Given this list of marker genes Lsm3, Dis3l2, Samd4b, Kif5a, Caprin1, Zc3h12d, Lin28a (lin-28 homolog A), Cnot1, Syne1, Igf2bp2 (NCBI Gene Id 319765), Top1, Patl2, Cnot9, Cpeb1, Trim12a, Lsm2, Trim21, Eif4e, Carhsp1, Fam184a, Elavl1, Ago2, Samd4, Lsm6, Xrn1, Pan3, Psma4, Eif4e2, Psmc2, Ythdf3, Tnrc6c, Pum1, Trim30c, Dcp1a, Garre1, Cnot2 (CCR4-NOT transcription complex, subunit 2), Edc3 (NCBI Gene Id 353190), Trim30d, Psma2, Ybx1, Upf1, Sqstm1, Ddx6, Patl1, Mex3a, Cnot7, Dcp2, Trim71, Zc3h12a, Igf2bp3, Tnrc6b, Apobec3, Zfp36, Lsm1, Dcp1b, Ago4, Nbdy, Mex3b, Trim30a, Btbd1, Trim30b, Nanos3, Btbd2, Nanos2, Ago3, Zfp36l1, Cnot8, Lsm14a, Tnrc6a, Edc4, Ythdf2, Csde1, Ythdf1, Ajuba, Wtip, Ago1, Rc3h2, Cnot3, Rbpms, Aicda, Psmc3, Shfl, Igf2bp1, Trim12c, Dcps, Polr2g, Mir23a, Isg20, Noct, Lsm4, Psma6, Pnrc2, Mov10, Limd1, Trim5, Pan2 (PAN2 poly(A) specific ribonuclease subunit), Rc3h1, Hax1, Pnrc1, C9orf72, Eif4enif1, here is a description of the gene set: A focus in the cytoplasm where mRNAs may become inactivated by decapping or some other mechanism. Protein and RNA localized to these foci are involved in mRNA degradation, nonsense-mediated mRNA decay (NMD), translational repression, and RNA-mediated gene silencing. Mouse Gene Set: GOCC_P_BODY studied in species Mus musculus